The following is a description of a gene set: studied in species Homo sapiens Poor speech Human Gene Set: HP_POOR_SPEECH, and this is the list of marker genes: LRPPRC, MID1, UBE4B, OPHN1, INPP5E, SLC35A1, PLPBP, HDAC8, CDC42, NUBPL, YME1L1, NDUFA6, DIAPH1, TELO2, NAA20, PPP1R15B, SLC39A8, UQCC2, SPEN, PPP2R5D, SMC3, PPP2R1A (protein phosphatase 2 scaffold subunit Aalpha), GATAD2B, CHSY1, KANSL1, CAMK2G, PRKCZ, ALG9, GNPTAB, SARDH, CCDC22, HSPG2, GAS1, DYM, CNTNAP2 (NCBI Gene Id 26047), VLDLR, SYT1, FRMD4A, ATAD3A, RAB39B, KCNAB2, MRPS2, TSC1, CSF1R, PUS3, NDST1, DISP1, UBE2A, KIF15, NALCN, FBXL3, ATP1A1, AHDC1, IFNG, WDR45, ITPR1 (NCBI Gene Id 619543), NGLY1, TRAPPC10, TUBB4A, CASZ1, HNRNPK, SMARCA2, TGIF1, OCA2, TMEM106B, CHMP2B, PLCH1, WIPI2, KMT2B, IQSEC2, PTCH1, FKRP, CDON, ATP6V1A, MTO1, GUSB, GAMT, RILPL1, TAF2, CAD, FGF12, MMP23B, ATP6V0A2, GATA4, ATP6V1E1, EIF2S3, APC2, FOXH1, CIC, ODC1, ADK, KIF14, TRMT10A, SLC6A17, ZIC2, VPS11, FMN2, FOXP2, FGF8, POMT1, SET, EXT2 (NCBI Gene Id 2132), RTTN, LARGE1, AP4E1, BRF1, TRAPPC11, FDXR, TRRAP, AP4M1, DOCK7, SLC39A14, GLI2, MID2, PAK1, POMK, MAB21L1, NDUFA13, EBF3, TRMT5, NAGS, CHMP1A, CLIC2, TBCK, PSEN1, DAG1, STIL, TSC2, SASS6, PAK3 (NCBI Gene Id 5063), GMPPB, SATB2, ASPA, COG8, NDUFS1, SYNGAP1, WDR73, SIX3, LUZP1, SKI, SNAP25, VCP, PIGC, HEPHL1, RAC1, POMT2 (protein O-mannosyltransferase 2), UBE3A, GRN, RLIM, GJC2, ZNF148, GPR88, DYRK1A, RNASET2, NONO (non-POU domain containing octamer binding), PIGH, PDPN, MAPT, SHH (sonic hedgehog signaling molecule), SNRPN, HS6ST2, LAS1L, ATP10A, UNC80, PYCR2, RERE, KAT6A, ATP6V1B2, DLL1, TREM2, AP4S1, SLC19A3, SMC1A, SQSTM1, AP1S2, FOXRED1, TAF6, SOBP, MED13L, ADPRS, CTNNB1 (NCBI Gene Id 1499), STAG2 (STAG2 cohesin complex component), TBCD (tubulin folding cofactor D), CHKB, MED25, TUBB3, FGFR1, AP4B1, CRIPTO, MAN1B1, PRDM16, TRIO, ZEB2, NODAL, GABRD, DLAT